The following is a description of a gene set: part of: Mucopolysaccharidoses Mucopolysaccharidosis I (MPS I, Hurler syndrome, Hurler's disease, gargoylism, Scheie, Hirler-Scheie syndrome; MIM:607014, 607015 and 607016) is an autosomal recessive genetic disorder where there is a deficiency of alpha-L iduronidase (IDUA, MIM:252800), a glycosidase that removes non-reducing terminal alpha-L-iduronide residues during the lysosomal degradation of the glycosaminoglycans heparan sulphate and dermatan sulphate. In 1992, Scott and colleagues were able to clone and purify the gene that encodes this enzyme, IDUA, demonstrating that it spans approximately 19 kb and contains 14 exons.<br>Hurler syndrome is named after a German paediatrician Gertrud Hurler (1919, no reference available). The result is build up of heparan sulfate and dermatan sulfate in the body and increased urinary excretion of these GAGs. Symptoms and signs include hepatosplenomegaly, dwarfism, unique facial features, corneal clouding, retinopathy, progressive mental retardation appears during childhood and early death can occur due to organ damage (Campos & Monaga 2012). MPS I is divided into three subtypes, ranging from severe to mild phenotypes; Mucopolysaccharidosis type IH (MPSIH, Hurler syndrome, MIM:607014), mucopolysaccharidosis type IH/S (MPSIH/S, HurlerScheie syndrome, MIM: 607015) and mucopolysaccharidosis type IS (MPSIS, Scheie syndrome, MIM: 607016) respectively. Reactome Pathway: MPS I - Hurler syndrome (CS/DS degradation) species: Homo sapiens, and this is the list of marker genes: IDUA